Given this list of marker genes SF3A1, SF3A3, SF3A2, SF1, ISY1, SLU7, here is a description of the gene set: Human Gene Set: GOBP_MRNA_3_SPLICE_SITE_RECOGNITION Recognition of the intron 3'-splice site by components of the assembling U2- or U12-type spliceosome. studied in species Homo sapiens